Given this list of marker genes TBX2, MTA1, SNAI2, TGFB1, MYOZ1, THRA, TFEC, GLIS3, TGIF2LY, PPP1R13L, SKOR1, HESX1 (NCBI Gene Id 8820), OVOL1 (ovo like transcriptional repressor 1), NFATC2, MLIP, MBD3L2B, ZNF345 (zinc finger protein 345), HDGF, DNAJA3, ZNF239, PTPN2, HDAC4, SOX3, VAX2, PPARG, SINHCAF, EN1, ZNF354B, IFI16, MCPH1 (microcephalin 1), ELK4, RTF1, IRX1 (iroquois homeobox 1), MMP12, OSR2, ZBTB5, SNAI3, CIC, CHD4, EZH1, ATXN1, PPARD, TBX18, GZF1, TBX6, ZBTB4, MACROH2A2, ZBTB12, DACT1, SSX1 (SSX family member 1), ETV3, COPS2, LOXL2, ANKRD2, RREB1, JAZF1, CDKN2A, FOXE1, MXD1, PCGF6, ZNF254, NFKBIA, HSF4, RBPJ, TMPRSS6, CEBPB, FAM220BP, RPS14 (ribosomal protein S14), NR1H3, MIER3, ZBTB16, KANK2, ID1, LEP, NOTCH4, SIX1, FBP1, WNT10B, SOX14, ZBTB26, HDAC10, BCL11A, VAX1, SARNP, TAF3, NANOG, GABPA, VHL, POU1F1, NR1I2 (NCBI Gene Id 8856), NR1I3, SUPT5H, IL33, PRDM5, NR1H2, PCGF2, BACH2, SDR16C5, EGR1, FAM220A, HMBOX1, CAV1, PRDM1, ZFPM2, TXNIP, MAGEB1, MBD3L2, SFPQ, KHDRBS1, GPS2, JUN, ZGPAT (zinc finger CCCH-type and G-patch domain containing), HIPK2, CIITA, ARID4A, ARID5A, CBX2, AASS, ESR1, NR4A3, SREBF1, KLF8, PAF1, GFI1B, DPF2, HDAC1, NCK2, PARP15, ZNF675, PLK1, AURKB, FOXH1, LMO4, E2F7, MAGEA9, RLIM, ZNF217, SOX13, ZNF431, ING1, NSMCE3, COQ7, TRIB1, DLG1, TNF, RARG, LDB2, ARID5B, DLL4, SORBS3, MNX1, NR1H4, PRDM12, KLF7, RARA, BTG2, ZNF746, ZNF668, CBFB, ZHX1, MYT1L, AEBP1, NIF3L1, TPR, FOXA2, FEZF2, RPL23, TRO, HNF1B, DEAF1, DMBX1, FZD6, KDM5A, POU4F1, PSMD10, HMGB1, HDAC3, MORC3, MIER2, EFNA1, NFE2L1, NCOA5, FOXP2, POU4F2, ZBTB20, PITX2 (paired like homeodomain 2), CC2D1A, PER1, TCF7L2, SUPT4H1, ZNF692, KLF3, NEUROG3, STAT1, GSC, FOXO3, SNW1, LEF1, TP63, SFN, STAT3, TET1, NR6A1, FOXP4, TFAP2C, SIRT6, ZNF131, CREBBP (NCBI Gene Id 1387), VPS72, IGBP1, SGF29, PRDM2, GSTP1, NR2C1, MAGEB16, MAGED4B, HDAC2, APBB1, MBD3L5, MAGEA9B, NODAL, MAGEC2, HAND1, ZBTB49, H1-3 (NCBI Gene Id 3007), ZNF133, DCAF1, PHF6, FGF9, GATA2, PROP1, VSX2, BARX2, PIAS3, FGFR1, SRC, FERD3L, NACC1, DUSP26, LMCD1, KLF12, VEGFA, ZNF451, SUFU, FOXL2, MLXIPL, IRX4, BIN1, ZNF536, DACH1, KAT14, MAGEA4, ESX1, TBX22, ING2, NCOR1, DNAJB5, SIRT2, MXD3, MAGEB6, TNFSF4, MAP2K5, PRMT6, ANKRD1, CTCF, NFATC4, TAL1, TBXT, ZBTB37, CTR9, NFKB1, AMOT (angiomotin), CBX7 (chromobox 7), MAFK, BHLHE41, ZNF93, NELFE (NCBI Gene Id 7936), SCGB1A1, KEAP1, ETS2, FGFR2, NPAS1, RB1, MAGEA2, ASCL1, YBX3, NKX2-5, CALR, JDP2, REST, BEND3, CNOT2, BCL6, EDN1, ZNF274, OLIG3, FOXR1, RFX5, NRIP2, BPTF, ATF3, MAGEA11, MYPOP, ZEB1, GTF2IRD1, TWIST1, DUSP22, IRX3, OSR1, DDX20, EHMT1 (euchromatic histone lysine methyltransferase 1), PRDM13, ZBTB32, ARID4B, HIC2 (NCBI Gene Id 23119), UBE2I, KAT2A, MDM4, MACROH2A1, FLYWCH1 (NCBI Gene Id 84256), TBX20, FOXS1, MAZ, HINFP, PLAGL1, MXI1, MAGEB10, MED25, ZEB2, EPO, IRF2BPL, TCF3, HDAC5, ZBTB7A, ZNF750, E4F1, ELK3, MAGEA1, ZBTB8A, PDE2A, ZNF141, NCK1, ID3, PRKN, SMURF2, TBX21, AEBP2, ZNF205, ZNF224, PRDM6 (NCBI Gene Id 93166), LIN37, TRIM27, SIK1, MAD2L2, NR2F1, SMAD3, FEZF1, OTUD7B, H3C13, GATA4, RORC, IFI27, ZMYND8, RIPPLY1, CDC73, NFIB, SPEN, NSD1, FOXM1, TENM2, FNIP1, HOXB3, GATA3, NFX1, CTNND1, CBFA2T2, EPC1, NKAP, NUPR2, PURA, RUNX3, TRAF6, NR1D1, SIN3B, MED1, RITA1, NR2F6, SNCA, NRARP, SIRT1, PKIA, SOX15, SPDEF, PATZ1, NKX2-1, RYBP, SOX10, SUDS3, CHD3, CREB3L1, ZNF268, ENO1, PARP9, ZNF572, OGT, WWC1, CDKN1C, TSG101, HOXA2, HJV, ZBTB18, HSF1, MAGEB3, PHF21A, ZHX3, PRNP, NKX3-1, SAP130, SKIL, NR1D2, CITED2, ZNHIT1, MBD3, PIAS4, MZF1, NCOA2, GADD45A, HCFC1, H3C15, IRF8, DR1, CDX2, UBE2D1, HOXB13, HSPA1A, DKK1, STRAP, MSC (musculin), ASCL2, SATB1, TLE4, IRX2, DNAJB4, NACA, HOXA7 (homeobox A7), BHLHE40, PHF14, ZC3H8, HDAC8, SAMD11, ZNF653, RUNX1, ZBTB17, RELA, THAP11, EID1, MXD4, SNAI1, DAB2, FOXD3, FOXG1, CXXC5, GLIS2, MEF2C, SMARCA4, LEFTY1, MAGEA12, ZBED2, TCFL5, KDM2B, DLX2, BATF3, CBX8, YBX1, HNRNPU, PKIG, FOXO1, MAGEB4, AMOTL2, MEIS2, ZNF8, PURB, MOSPD1, NR2E3, ZBTB46, ZMYM5, ZKSCAN3, MAGEA3, ZC3H12A, HSBP1, MAGED4, FOXJ1, ZFP92, TBL1X, SOX1, GATA5, WDR5, TRPS1, MAEL, KCNIP3, TLE5, CRYM, MAGEB18, USP2, SOX12, TAF7, ZBTB33, TBX3, MBD3L1, NFATC3, HES2, HHEX, ATF7IP, MBD1, SOX21, TXN, GATA1, THAP7, HEXIM2, MDFI, MYOZ2, FRK, H1-2, SHOX2, HOPX, EP300, E2F6, GLI3, NR4A2, WT1, HES1, FOXP1, CCND1, SP3, MAGEA2B, MAGEA6, ZNF175, MYB, SKI, RPL10, LARP7, NKX6-3, KAT2B, SLA2, MAGED2, IRF2, NFIX, DNMT1, CCNE1, SP2, CRY1 (NCBI Gene Id 1407), HMGA2, ZGLP1, S100A1, RARB, NR2E1, CIR1 (NCBI Gene Id 9541), SOX9 (SRY-box transcription factor 9), DLX4 (distal-less homeobox 4), MBD3L3, IL4, CEBPA, ZNF174, EZR, OLIG2, ZFP90, WWP2, RALY, YY1, MLX, SHH, TNFSF11, KLF5, GATAD2A, CPEB3 (NCBI Gene Id 22849), HDAC9, CDK6, SUZ12, PHF19, E2F1, FOXF1, ATF4, MNT, ALX1, SCRT2, TRPV1, RIPPLY3, MTDH, ZBTB1, HAMP, GLI2 (NCBI Gene Id 50806), GATA6, XPO1, TAF9B, TCP10L, BMP2, MAGEE1, DNMT3A, CUL3, N4BP2L2, MAFF, ZNF683, FOXA1, ISL1, ZNF281, PAX6, BRMS1, MAGEL2, SAMD1, GFI1 (growth factor independent 1 transcriptional repressor), CD36, FOXK1, SMAD7, MAGEB6B, ZHX2, MYC, WWC3, CTNNBIP1, ZBED6, TGIF2, PROX1, ZNF134, HDAC7, ZNF263, HOXB8, ZNF469, MAGEH1, GLIS1, YWHAZ, ORC2, ARX, TRIB3, DICER1, SKOR2, ZNF202, ACE2, HIC1, SOX2, MEF2A (myocyte enhancer factor 2A), ZFP36, TNFRSF4, MECP2, PER3, SFRP4, MAGEB2, ZNF350, HEY2, TAGLN3, PPM1A, HMG20A, MBIP, IGF2, CTBP2, IKZF5, TRIM29, SP5 (Sp5 transcription factor), WWC2, JARID2, FNIP2, NIPBL, PEG3, ZBTB25, SIN3A, YEATS2, MAGED1, SMARCA2, SAP30L, HOXD9 (NCBI Gene Id 3235), LRRFIP1, IMPACT, POLE3, JPH2, NCOR2, DDIT3 (DNA damage inducible transcript 3), KLF2, ZFPM1, CTBP1, MAGEA10, DNAJC17, NOTCH2, TCF21, DRAP1, EDNRB, KLF10, MDM2, MAGEE2 (NCBI Gene Id 139599), SAP30, TRIM33, TGIF1, SAMD7, MEPCE, ATN1, TDG, SOX4, HMX1, ZNF136, ESRRA, UXT, ZBTB39, POU6F1, FOSB, THRB, MBD2, NR2C2, ATXN1L, SALL1, PIAS1, FLCN, AR, SQSTM1, YAP1, MAGEC1, ETV5, NOTCH1, IFNG, SMAD4, CC2D1B, DMRT1, NRIP1, TADA3, FOXC2, CREM, FOXP3, TFAP2A, VDR, PPID (peptidylprolyl isomerase D), APBB2, MAGEC3, PTPRC, CUX1, AJUBA, KMT5A, RNF2, MTA3, PPARA, DDX5, ANXA4, DLX1, FOXK2, KLF16, SUV39H1, TCF23, ZBTB21, UBE2D3, SCRT1, URI1, CNBP, NR2F2, DNMT3B, TAF1, PCBP3, OVOL2, FHL2, ZBTB2 (NCBI Gene Id 57621), PHB1, SOX18, HES6, MAFB, TMBIM6, HMGB2, PDX1, OTP, CBX4, MAGEA8, TCERG1, ZNF512B, ACVR2B, HOXD8 (homeobox D8), STRN3, RBBP4, SALL4, IRF7, PCNA, ZBTB10, KLF11, MAF, SOX8, CRY2, SCAF8, E2F8, FBLN5, INSM1, CUX2, HEYL, TBX15, XBP1, ZNF559-ZNF177, SREBF2, MTA2, ZNF366, MIER1, SOX11, BCORL1, MAGEB17, HEXIM1, KDM1A, TGIF2LX, PLA2G10, MBD3L4, RFC1 (replication factor C subunit 1), IRF2BP2 (interferon regulatory factor 2 binding protein 2), C1QBP, NEDD4, RBBP7, HCFC2, NFE2L3, PRRX1 (paired related homeobox 1), PSEN1, BTRC, BRMS1L (BRMS1 like transcriptional repressor), MAX, EED, TRIM28, RIPPLY2, SARS1, PER2, FOXC1, MYOCD, RXRA, NOG, TSC22D4, SATB2, TRPV4, JUND, TP53, ZBTB34, SDCBP, THAP5, NOTCH3 (notch receptor 3), FOXQ1, CHD8, FASLG, H3C14, DNAJB1, RBM10, ENG, ESR2, NDN, MSX2, ZBTB45, MAFG, HBZ, ZNF304, KAT5, RBL1, NR0B1, LCOR, IRF2BP1, MAGEA13P, USP9X, ASCL3, CNOT1, CDX4, RIF1, APP, SEMA4D, EID2, BCL6B, HEY1, HES7, NFIC, ZNF296, DUSP15, ELANE, HIVEP1, WWTR1, ZNF568, LYAR, BMP4, EN2, POU5F1, HIF1AN, SCAF4, ERF (NCBI Gene Id 2077), SIM2, HOXC8, ZFHX3 (NCBI Gene Id 463), WFS1, ZBTB14, TBL1XR1, ZNF219, MIR128-1, CREBRF, CELA1, TLE6, PTCH1, NKX6-1, MITF, SOX30, SMO, CTNNB1, FST, PAX5, H1-5, ZNF91, BACH1, DMAP1, LMO1, NR0B2, SMYD2, ZBTB7B, NR3C1, ATF7, ID4, ETV6, SPI1, PRDM14, NACC2, CDK2, ATF2, GATAD2B, SUV39H2, ETV7, ZBTB42, ZNF608, INSM2, ZBTB6, ZNF140, CBX6, PHF12, NKX3-2, SIRT7, STAT6, HOXB4, MSX1, ZNF354C, TFCP2L1, BMI1, HES5, CBX5, PAWR, ZNF148, SMAD5, BMP6, ZNF589, LDB1, MAGEF1, TRIM37, NKX6-2, HELT, PLK3, TFAP2B, BCOR, ZNF85, CGGBP1, ID2, EZH2, UHRF1, MEN1, HCLS1, NSD2, KLF4, DAB2IP, MAGEB5, NOP53, PRDM16, H1-4, PCGF1, WDTC1, EHMT2, NFIL3, ZNF177 (NCBI Gene Id 7730), NOC2L, PARP1, CCND3, EOMES (eomesodermin), SP100, IRF3 (NCBI Gene Id 3661), THAP1, here is a description of the gene set: Human Gene Set: GOBP_NEGATIVE_REGULATION_OF_TRANSCRIPTION_BY_RNA_POLYMERASE_II studied in species Homo sapiens Any process that stops, prevents, or reduces the frequency, rate or extent of transcription mediated by RNA polymerase II.